The following is a description of a gene set: Human Gene Set: HP_ABNORMAL_PEER_RELATIONSHIPS species: Homo sapiens Abnormal peer relationships The state of having abnormal relationships with others. This does not describe specific aspects of one's social aptitudes but rather a state which may come about from these aptitudes, such as lacking peer relationships or lacking close friends., and this is the list of marker genes: NLGN4X, AP2M1, MECP2, SLC6A1, NLGN3, CHD2, SLC2A1, SYNGAP1, NEXMIF (NCBI Gene Id 340533), SCN1A